Given this list of marker genes FERMT1, RREB1, HTN1, MTOR, MIR221, FERMT2, here is a description of the gene set: Any process that activates or increases the frequency, rate or extent of wound healing, spreading of epidermal cells. species: Homo sapiens Human Gene Set: GOBP_POSITIVE_REGULATION_OF_WOUND_HEALING_SPREADING_OF_EPIDERMAL_CELLS